The following is a description of a gene set: species: Homo sapiens Human Gene Set: HP_RENAL_MALROTATION An abnormality of the normal developmental rotation of the kidney leading to an abnormal orientation of the kidney. Renal malrotation, and this is the list of marker genes: FIBP, STRA6, RBM8A, PAX2 (NCBI Gene Id 5076), SOX11, SALL4, SIX1, EYA1